The following is a description of a gene set: Increased theta frequency activity in EEG Increased frequency of theta wave activity in the electroencephalogram. Theta waves have a frequency of 3.5-7.5 Hertz, and are present in very small amounts in healthy waking adult EEGs. Theta activity is normal in small very amounts in the healthy waking adult EEG in a symmetrical distribution. species: Homo sapiens Human Gene Set: HP_INCREASED_THETA_FREQUENCY_ACTIVITY_IN_EEG, and this is the list of marker genes: CHRNB2, CABP4, KCNQ3, CHRNA2, DEPDC5, RPL10, CHRNA4, CRH, SETD1B, KCNQ2, KCNT1